Given this list of marker genes RALA, CEP68, EEF2K, NR5A2, ZNF436, GIMAP1 (GTPase, IMAP family member 1), INKA1, RHOBTB1, SUOX, MAFB, MLYCD, SPTLC2, CLEC14A, FRY, RAB11A, GIT2, TXNIP, EPHA4, KLHL3, HLX, VGLL4, FAM78A, SAMD13, ZKSCAN4, TRIM34, SESN1, here is a description of the gene set: Oxidized phospholipids are thought to promote atherogenesis by stimulating endothelial cells (ECs) to produce inflammatory cytokines, such as IL-8. In studies with mouse models, we previously demonstrated that genetic variation in inflammatory responses of endothelial cells to oxidized lipids contributes importantly to atherosclerosis susceptibility. We now show that similar variations occur in cultured aortic ECs derived from multiple heart transplant donors. These variations were stably maintained between passages and, thus, reflect either genetic or epigenetic regulatory differences. Expression array analysis of aortic EC cultures derived from 12 individuals revealed that >genes were regulated by oxidized phospholipids. We have used the observed variations in the sampled population to construct a gene coexpression network comprised of 15 modules of highly connected genes. We show that several identified modules are significantly enriched in genes for known pathways and confirm a module enriched for unfolded protein response (UPR) genes using siRNA and the UPR inducer tunicamycin. On the basis of the constructed network, we predicted that a gene of unknown function (MGC4504) present in the UPR module is a target for UPR transcriptional activator ATF4. Our data also indicate that IL-8 is present in the UPR module and is regulated, in part, by the UPR. We validate these by using siRNA. In conclusion, we show that interindividual variability can be used to group genes into pathways and predict gene-gene regulatory relationships, thus identifying targets potentially involved in susceptibility to common diseases such as atherosclerosis. Human Gene Set: GARGALOVIC_RESPONSE_TO_OXIDIZED_PHOSPHOLIPIDS_RED_DN Genes from the red module which are dn-regulated in HAEC cells (primary aortic endothelium) after exposure to the oxidized 1-palmitoyl-2-arachidonyl-sn-3-glycerophosphorylcholine (oxPAPC). species: Homo sapiens from publication Gargalovic PS, Imura M, Zhang B, Gharavi NM, Clark MJ, Pagnon J, Yang WP, He A, Truong A, Patel S, Nelson SF, Horvath S, Berliner JA, Kirchgessner TG, Lusis AJ (PMID 16912112)